Given this list of marker genes Piezo1, Nln, Cav3, Tbx1, Hdac4, Plpp7, Bhlhe41, Fbxo22, Bdnf, Hdac5, Myod1, Rbm24, Mtor, Atp11a, Bhlha15, Sik1, Bcl2, Trim72, Nkx2-5, Actn3, Lmod3, Csf1r, Neu2, Shox2, Myf6, Rpl3l, Dmpk, Notch1, Csrp3, Cyp26b1, Daxx, Myocd, Mamstr, Myog, Rbm38, Maml1, Xbp1, Smyd1, Ankrd2, Mmp14, Ccn3, Hdac9, Myf5, Mapk14, Tmem119, here is a description of the gene set: Any process that modulates the frequency, rate or extent of myotube differentiation. Myotube differentiation is the process in which a relatively unspecialized cell acquires specialized features of a myotube cell. Myotubes are multinucleated cells that are formed when proliferating myoblasts exit the cell cycle, differentiate and fuse. species: Mus musculus Mouse Gene Set: GOBP_REGULATION_OF_MYOTUBE_DIFFERENTIATION